The following is a description of a gene set: species: Homo sapiens Human Gene Set: ZAK_PBMC_MRKAD5_HIV_1_GAG_POL_NEF_AGE_20_50YO_CORRELATED_WITH_CD8_T_CELL_RESPONSE_3DY_NEGATIVE To better understand how innate immune responses to vaccination can lead to lasting protective immunity, we used a systems approach to define immune signatures in humans over 1 wk following MRKAd5/HIV vaccination that predicted subsequent HIV-specific T-cell responses. Within 24 h, striking increases in peripheral blood mononuclear cell gene expression associated with inflammation, IFN response, and myeloid cell trafficking occurred, and lymphocyte-specific transcripts decreased. These alterations were corroborated by marked serum inflammatory cytokine elevations and egress of circulating lymphocytes. Responses of vaccinees with preexisting adenovirus serotype 5 (Ad5) neutralizing antibodies were strongly attenuated, suggesting that enhanced HIV acquisition in Ad5-seropositive subgroups in the Step Study may relate to the lack of appropriate innate activation rather than to increased systemic immune activation. Importantly, patterns of chemoattractant cytokine responses at 24 h and alterations in 209 peripheral blood mononuclear cell transcripts at 72 h were predictive of subsequent induction and magnitude of HIV-specific CD8(+) T-cell responses. This systems approach provides a framework to compare innate responses induced by vectors, as shown here by contrasting the more rapid, robust response to MRKAd5/HIV with that to yellow fever vaccine. When applied iteratively, the findings may permit selection of HIV vaccine candidates eliciting innate immune response profiles more likely to drive HIV protective immunity. from publication Zak DE, Andersen-Nissen E, Peterson ER, Sato A, Hamilton MK, Borgerding J, Krishnamurty AT, Chang JT, Adams DJ, Hensley TR, Salter AI, Morgan CA, Duerr AC, De Rosa SC, Aderem A, McElrath MJ (PMID 23151505) Genes negatively correlated with CD8+ T-cell response in peripheral blood mononuclear cell in adults (20-50) after exposure to MRKAd5 HIV-1 gag/pol/nef, time point 3D, and this is the list of marker genes: TIFAB, MIR1250, ARC, MIR219A1, SPSB4, DLX1 (NCBI Gene Id 1745), CHKB, UBAP1L, ELFN1, KRTAP10-3, TEX28, SSTR5, RNU12, AZU1 (azurocidin 1), PRR29, TTC6, FOXH1, ACTL9, LCE3A, LCE1F, DUSP15, TMEM92, PSORS1C2, SFTPD, CLCNKA, PRAP1, MIR598, LHFPL4, LRRC3C, CRYBB3, PCDHA13, KRTAP10-4, KRTAP10-1, SNORA80B, ENSG00000254531, SLC35G6, CCDC180, ASS1, RPL7A, RBAK-RBAKDN, LRRC30, FAM153A, GJA4, LURAP1, TGFBR3L, MIR1909, CCN5, CSRP2, MRPL23-AS1, PSCA, TCEAL3, KCNF1, CCDC188, NKX6-1, TMEM210, LINC01144, LY6H, TPSD1, NPAP1, MIR1225, ANXA8L1, LY6D, PROP1, PPP3R2, CLDN19, DEFB132, MOGAT3, CRIP3, KRTAP12-4, MIR636, GNG8, PTGER1 (NCBI Gene Id 5731), NPB (neuropeptide B), CENPM, MALL (mal, T cell differentiation protein like), LYPD2, ANKRD63, SOX15, BHLHA9, NUTM2A-AS1, KRTAP10-12, DUSP9, CTRB1, MIR132, PRRT2, OLMALINC, PRSS3, GPIHBP1, HSALR1, PIP5KL1 (phosphatidylinositol-4-phosphate 5-kinase like 1), NPPC, SLC38A8, GUCA2B, ARTN, KCNG2, UPK3B, GPR37L1, GPR152, EFNA2